Given this list of marker genes Slc11a1, Nod1, Ccl21a, Nod2, Ccl19, Ccr7, Cd74, here is a description of the gene set: Any process that activates or increases the frequency, rate, or extent of dendritic cell antigen processing and presentation. studied in species Mus musculus Mouse Gene Set: GOBP_POSITIVE_REGULATION_OF_DENDRITIC_CELL_ANTIGEN_PROCESSING_AND_PRESENTATION